The following is a description of a gene set: Any process that activates or increases the frequency, rate or extent of leukocyte proliferation. studied in species Mus musculus Mouse Gene Set: GOBP_POSITIVE_REGULATION_OF_LEUKOCYTE_PROLIFERATION, and this is the list of marker genes: Mpl, Cd6, Tnfsf4, Csf1r, Il23a, Ighd, Bcl2, Il3, Card11, Cd40, Tgfbr2, Il18, Il15 (interleukin 15), Slc4a1, Mef2c, Anxa1, Cd3e, Il6, Il12b, Csf2ra, Tcf3, Xcl1, Pdcd1lg2, Fadd, Ada, Wnt3a, Traf6, Sash3, Ripk2, Jak3, Cd38, Selenok, Aif1, Cd4, Ppp3ca, Peli1, Nmb, Igf2, Igf1, Csf1, Cd244a, Cd81, Il7, Itgal, Tnfsf13, Dhps, Hes1, Shh, Il2, Irgm1, Cd276, Tlr4, Rasal3, Kit, Clcf1, Tnfsf9, Tirap, Gpr183, Ccl5, Tacr1, Il1b, Nfatc2, Tlr9, Bst1, Spn, Prkcq, Foxp3, Csf2rb, Zfp335, Jak2, Ighm, Cd59a, Cd59b, Il1a (interleukin 1 alpha), Cd274, Vcam1, Il12rb1, Cd46, Cd1d2, Tyk2, Pth, Mapk3, H2-T23, St6gal1, Pycard, Lep, Mapk1, Pnp, Il4, Ccr2, H2-DMb1, Nr5a2, Ptk2, Tnfrsf13c, Zp3, Slc7a1, Irs2, Efnb1 (ephrin B1), Syk, Il21, Gsk3b, Nck1, Ptprc (protein tyrosine phosphatase receptor type C), Ccdc88b, Slamf1, Il2ra, Dnaja3, Tfrc, Il6st, Hmgb1, Il13, Lyn, Il12a, Fgf10, Cd24a, Myd88, Btk, Cd209c, Ticam1, Mif, Cd40lg, Flt3l, Tnfsf13b, Ephb2, Igfbp2, Rps3, Cd209e, Cd28, Tac1, Blm, Ccr7, Bcl2l1, Cd55b (CD55 molecule, decay accelerating factor for complement B), Ccl19, Havcr2, Nmbr, Cd74, Stat5a, Cd80, Csf2, Bcl6 (B cell leukemia/lymphoma 6), Ifng, Bmi1, Ptpn22, Cd209d, Gpam, Adk, Zap70, Kitl, Csf2rb2, H2-DMb2, Cd86, Nck2, Rac2, Slc39a10, Vtcn1, Ager, Cdkn1a, Coro1a, Carmil2, Stat5b, Tnfrsf4, Cd320, Epo, Il34, Prlr, Btnl2, Il5, Cd55, Atad5, Chrnb2, Icosl, Spta1, Ocstamp, Cd1d1, Vav3, Nckap1l